The following is a description of a gene set: studied in species Homo sapiens Human Gene Set: REACTOME_REGULATION_OF_TP53_EXPRESSION_AND_DEGRADATION Regulation of TP53 Expression and Degradation, and this is the list of marker genes: PPP2CB, CCNA2, PPP2CA, PPP2R1A, AKT1, PPP2R1B, CDK2, RPS27A, UBC, AKT2, PRDM1, TP53, CDK1, ATM, CCNG1, PDPK1, CDKN2A, PPP2R5C (NCBI Gene Id 63377), MAPKAP1, AKT3, CCNA1, MLST8, RNF34, RFFL, SGK1, UBB, PHF20, USP2, RICTOR, CHEK2 (checkpoint kinase 2), PRR5, DAXX, MDM4, USP7, MDM2, UBA52 (NCBI Gene Id 7311), MTOR